Given this list of marker genes CAMK2B, SYNE1, LONP1, SYNE2, MYCN, PRX (NCBI Gene Id 57716), ATXN3, POLR1A, SDHAF2, PMP22 (NCBI Gene Id 5376), TNNC2 (NCBI Gene Id 7125), MATR3, SBF2, FH, ADCY6, RILPL1, LRP12, DST, TRIM2, VHL, SDHA, SLC52A3, SDHD, RET, DLST (dihydrolipoamide S-succinyltransferase), GDAP1, ZNF699, DNMT3A, HAAO, NF1, TRAPPC12, MYH14, SDHC, GIPC1, TRPV4, SH3TC2, MAX, KIF1B, TMEM127, ELN, SETBP1, LMNA, EPAS1, DCTN1, NOTCH2NLC, TMEM43, SLC5A7, SLC25A11, SDHB, EMD, MLXIPL, SCO2, MFN2, FHL1, DKK1 (dickkopf WNT signaling pathway inhibitor 1, NCBI Gene Id 22943), JAG1, POLA1, MDH2, here is a description of the gene set: studied in species Homo sapiens A loss of the ability to move the vocal folds. Human Gene Set: HP_VOCAL_CORD_PARALYSIS Vocal cord paralysis